The following is a description of a gene set: studied in species Homo sapiens from publication Chen Y, Wang X (PMID 31504780) Human Gene Set: MIR3117_3P Genes predicted to be targets of miRBase v22 microRNA hsa-miR-3117-3p in miRDB v6.0 with MirTarget v4 prediction scores > 80 (high confidence targets)., and this is the list of marker genes: PAPOLB, CADPS, HAVCR1, UBXN10, ZHX2, CHM, KRAS, ZNF441, FAM120C, SYNCRIP, DISC1, SCUBE2, ZNF680, AZI2, FAM222B, ASNS, AFTPH, STAG2, ANO4, LRRTM4, C21orf91, GLRA2, RALA, PSAT1, APOL6, NID1, COLGALT2, NAP1L3, DIP2B, LHX2, GPT2, CLDN18, CSRNP3, KHDRBS1, CD274